The following is a description of a gene set: species: Homo sapiens Human Gene Set: WP_PHOTODYNAMIC_THERAPYINDUCED_NFKB_SURVIVAL_SIGNALING Photodynamic therapy-induced NF-kB survival signaling, and this is the list of marker genes: BIRC3, BCL2L2, IL6, EGLN2, CXCL8, MMP9, SELE, CSF2, BCL2A1, ICAM1, IKBKB, PTGS2, IL1B, BIRC5, VEGFA, BIRC2, IL2, TRAF6, MMP2, IL1A, MMP1, CXCL2, MMP3, CFLAR, NFKB2, CHUK, RELA, TNFRSF1A, REL, CCND1, TNF (NCBI Gene Id 7124), RELB, CD40LG, VCAM1, NFKB1 (nuclear factor kappa B subunit 1)